The following is a description of a gene set: Human Gene Set: GOBP_MAINTENANCE_OF_PROTEIN_LOCALIZATION_IN_ORGANELLE species: Homo sapiens Any process in which a protein is maintained in a specific location a specific location on or in an organelle, and is prevented from moving elsewhere. Encompasses establishment of localization in the membrane or lumen of a membrane-bounded organelle., and this is the list of marker genes: SYNE1, SUPT7L, ANKRD13C, CHCHD10, SUN2, AKT1, SKP1, ARL2, PINK1, PML, RER1, BARD1, KDELR1, HSPA5, KDELR3, TMED2, PGR, BBS4, FKRP, TXN, SUN1, RANGAP1, HDAC3, GPAA1, TAF3, TSPO, CDK5, INSIG2, HK2, TAF8, PARK7, NR5A1, PDIA2, FAM76B, KDELR2, ARL2BP, HK1, CIZ1, FREY1, OS9, INSIG1, TOPORS, SP100, MORC3, HNRNPU